The following is a description of a gene set: studied in species Homo sapiens Human Gene Set: GOBP_POSITIVE_REGULATION_OF_SMAD_PROTEIN_SIGNAL_TRANSDUCTION Any process that increases the rate, frequency or extent of SMAD protein signal transduction., and this is the list of marker genes: BMPR2, INHBA, AMH (NCBI Gene Id 268), SH2B1, GDF6, TGFB1, BMP10, BMPR1A, BMPER, GDF11, GDF2, ATOH8, NODAL, TTK, ACVR2A, TGFBR2, GDF5, ACVRL1, DAB2, GDF7 (growth differentiation factor 7), ENG, BMP6, BMP2, ACVR1, TGFB3, TGFBR3, TGFBR1, KIAA0319, TWSG1, NUP93, CSNK2B, TGFB2, SMAD3, GLCE, PSG9, BMP5, HFE, JAK2, PARP1, SMAD4, BMP4, BMP7